The following is a description of a gene set: Human infertility and recurrent pregnancy loss caused by implantation defects are poorly understood. Hoxa-10-deficient female mice have severe infertility and recurrent pregnancy loss due to defective uterine implantation. Gene expression profiling experiments reveal that Hoxa-10 is an important regulator of two critical events in implantation: stromal cell proliferation and local immunosuppression. At the time of implantation, Hoxa-10 mediates the progesterone-stimulated proliferation of uterine stromal cells. Hoxa-10 mutants express a stromal cell proliferation defect that is accompanied by quantitative or spatial alterations in the expression of two cyclin-dependent kinase inhibitor genes, p57 and p15. Hoxa-10 deficiency also leads to a severe local immunological disturbance, characterized by a polyclonal proliferation of T cells, that occurs in place of the normal progesterone-mediated immunosuppression in the periimplantation uterus. species: Mus musculus Genes co-regulated in uterus during a time course response to progesterone: SOM cluster 17. from publication Yao MW, Lim H, Schust DJ, Choe SE, Farago A, Ding Y, Michaud S, Church GM, Maas RL (PMID 12554760) Mouse Gene Set: YAO_TEMPORAL_RESPONSE_TO_PROGESTERONE_CLUSTER_17, and this is the list of marker genes: Arl3, Uqcrq, Lrpap1, Aldh9a1, Clpb, Tgfb1i1 (transforming growth factor beta 1 induced transcript 1), Lmnb2, Drap1, Eif4a3, Psmd8 (NCBI Gene Id 99154), Rnf7, Tnfaip1, Hsd17b4, Csnk2b, Cmbl, Nr2f6, Hacd3, Nme2, Ei24, Mrpl18, Grpel1, Usp1, Mrps12, Set, Stub1, Alg5, Erp29, Uri1, Lmna, Psma7, Dctn2, Vdac3, Plpp1, Smap1, Ndufab1, 4931406C07Rik (RIKEN cDNA 4931406C07 gene), Smdt1, Cops6, Txnrd1, Psmd14, Pias3, Inpp5a, Tomm70a, Impdh2, Ndufs6, Evl, Arl2bp, Ndufs3 (NCBI Gene Id 68349), Eif4e2, Ufc1, Ciao2b, Dpp3, Cks1b, Krt10 (NCBI Gene Id 319382), Vps25, Psmb5-ps, Mrpl34, Tpp1, Aqp4, Mrpl16, Taldo1, Twf2, Tmem109, Hypk, Ndufa11, Srsf9, Ccdc12, Crygd, Tmed10, Lypla1, D9Wsu149, Fuca1 (fucosidase, alpha-L- 1, tissue), Cenpb, Yipf5, Ddx54, Stard7, Bag1 (BCL2-associated athanogene 1), Ndufb6, Mrps14, Xrcc5, Ndufb9, Abracl, Cope, Arf4, Slirp, Hsd17b12, Cmpk1, Mrps34, Slc39a9, Exoc7, Gstp2, Mrpl2, Slc39a4, Mdh2, Krtcap2, Eef1akmt1, Mrps15, Naa10, Ubl4a, Lamtor1, Mrpl58, Coq7, Rpn2, Gclm, Lsm4, Trappc4, Ramp2 (receptor (calcitonin) activity modifying protein 2), Psmb7, Ube2s, Tor2a, Actb, Cdk4, Lias, Bcap29, Ptdss1, Mtif2, Gng10, Hmbs, Tcea1, Mrps11 (NCBI Gene Id 97380), Ddt, Ckb, Phb2, Polr3k, Psmg1, Nap1l1, Prelid1, Tmem160, Pdap1, Gosr2, Mrpl36, Ndufv2, Wtap, Serpina1a, Slc25a39, Capn2, Rxylt1, Hmgcs1, Sae1 (NCBI Gene Id 80447), Calm1, Psmd13, Bpgm, Romo1, Mrps22, Tubb5 (tubulin, beta 5 class I), Psmb6 (NCBI Gene Id 19175), Akt1, Cnih1, Fkbp1a, Mrpl51, Pdcd2, Cops5, Puf60, Faf1, Map3k7, Hnrnpd (NCBI Gene Id 330135), Erh, Parl, Tpm4, Uba1, Pcx, Eif1ax, Coro1c, Ercc3, Aurkaip1, Mapkapk2, Marcksl1, Sdhb (succinate dehydrogenase complex, subunit B, iron sulfur (Ip)), Ddx1, Dohh, Dlgap4, Ruvbl1, Ndufb7, Cyb5r1, Lsm7, Tram1, C030006K11Rik, Ddost, Fam162a, Yju2, Mrps7, Ifi35, Adsl, Dnajc19, Samm50, Rps6ka4